Given this list of marker genes SYT2, NUP88, SNORD116-1, NDUFB11, KDM6A, LMNA, IFNG, NEK9, NDUFB3, COQ4, DDRGK1, ERCC8, CACNA1S, TSC2, ALG8, CLXN, CPSF3, CHD7, PCDH12, CCDC134, ALPK3, RPL10, PPP3CA, SDHD, NEK8, CNTNAP1, VRK1, SLC30A7, ADGRG6, RPL26, NUP155 (NCBI Gene Id 9631), MEGF10, LGI4, TPM1, ZSWIM6, WDR45B, COASY, UBR1, DYNC2LI1, MKRN3, SHQ1, TMEM38B, B4GAT1, DLG5, CYP26B1, PPP1CB, SYNE1, FGF20, TRPV6, ASNS, IARS1, SOX18 (NCBI Gene Id 54345), ADCY6, ERF, MNS1, TNFRSF11A, SEC24D, GLUL, SCN4A, FH, MESP2, WNT4, SLC12A1, SNORD115-1, NSD1, PIGA, CC2D2A, PPIB, TBXT, FARSB, POMK, ALDH1A2, RMRP, CCDC88C, MPDZ, BICD2, POGZ, LZTR1, FGFR3, DVL1, ZIC2, XYLT1, TRAIP, MDFIC, NPAP1, SDHA, SRPK3, MRPS22, SIN3A, KIAA0753, GFRA1, MAP3K7, PAICS, ZIC3, BMPER, RAC1, TMEM218 (NCBI Gene Id 219854), ERCC5, RYR1, DCC, FZR1, CWC27, NDUFB7, ALG1, DEPDC5, PWRN1, NRIP1, ZBTB42, MKS1, BICC1, COL6A2, THSD1, COL2A1, SKIC2, SAMHD1, CHUK, DPH5, ACTA1, SLC35B2, SOS1, EXOC7, RAB34, OBSL1 (NCBI Gene Id 731094), CHRNG, SOX9, B9D1, IFIH1, KIF20A, SC5D, SCUBE3, GINS1, B9D2, KMT2B, GNPTAB, TWIST2, SLC35A3, GBE1, TBX5, PDX1, SERPINH1, ERI1, TRIP11, ACTG2, LMOD1, RAD21, EXOSC9, RAP1B, KIDINS220, TCTN3, SLC9A3, SNAP25, GRIP1, P3H1, RYR3, RECQL4, FTO, CALM2, CRB2 (crumbs cell polarity complex component 2), CILK1, DEF6, SLC30A9, TAF2, IL6ST, STRA6 (NCBI Gene Id 64220), CPT2, ATP1A2, ROBO1, SLC31A1, ZNF526, STT3B, WDR4, MCM10, TXNDC15, DDR2, PTH1R, PLEC, WNT3 (NCBI Gene Id 7473), FANCB, PKHD1, MAGEL2, MBTPS2, PRIM1, NDUFC2, LMNB1 (lamin B1), KLF1, TOGARAM1, HERC2, PYCR1, L1CAM, SLC35D1, NSD2, COX16, NRAS, RIPK4, TOP3A, SLC25A19, ASPM, LBR, KIF7, ALX4, CREB3L1, SOX10, PIGG, PLG, ZMPSTE24, CRTAP, WDR19, BUB1B, PLCH1, SCN5A, NAA20, KMT2D, PRRX1, TMEM216, CRLS1, MINPP1, PI4KA, LARS2 (NCBI Gene Id 23395), CHD8, CDC42BPB, ESAM, NADK2, FBXL4, DBR1, DLL3, RNU4-2, MYH11, COG8, GLDN, GUSB, RNU4ATAC, HCFC1 (NCBI Gene Id 8267), TBX18, RRAGC, KIF14, CENPE, BRD4, EIF5A, PLXND1, MYRF, EZH2 (NCBI Gene Id 392834), PLOD3, KDELR2, FKBP14, WT1, RNF2, DNM1, RSPO2, TNNT2, PWAR1, KIF5C, GBA1 (glucosylceramidase beta 1), PRKAG2, HNRNPK, USP18, CLPB, SMAD2, FARSA, here is a description of the gene set: species: Homo sapiens Onset prior to birth. Human Gene Set: HP_ANTENATAL_ONSET Antenatal onset